Given this list of marker genes Flcn, Ulbp1, Naa60, Pilra, Adap2, Cmklr1, Cd83, Irak4, Ptafr, Vwa5a, Lair1, Ptprcap, Rab7b, Gm11613, Gpr65, Fcgr2b, Napsa, Trim5, Ly86, P2ry13, Naip2, Tep1 (telomerase associated protein 1), Il1a, Slc22a3 (solute carrier family 22 (organic cation transporter), member 3), Arrb2, Sp110, Tbc1d4, Arhgap4, Rnf166, Ms4a6d, Ctsz, Asah1, E330020D12Rik, Naip6, Tmcc3, Gm21057, Snx8, Sp140, Cfp, Ccr1, Selenop, Clec5a, Dock10, Ncr3-ps, Fnbp1, Vsir, Pparg, Ctsd, C130050O18Rik, P2ry6, Clec4a3, Gm14221, Tmem141, Casp1, Laptm5, Cd48 (CD48 antigen), Mertk, Alpk1, Cnbd2, Tmem104, Ccr5, Tnfrsf11a, Dock2, Stk10, Cd37, Clta, Slc15a3, Gm5834, Tmem268, Adgre1, Osbpl8, Tpbgl, Tfe3, Pla2g15 (phospholipase A2, group XV), Paqr7, Fcgrt, Rubcnl (RUN and cysteine rich domain containing beclin 1 interacting protein like), Gm16124, E230029C05Rik, Lpar5, Slfn8, Cd53, Batf, Dynlt1a, Gm6213 (predicted gene 6213), Nfkbid, Grk2, Il10ra, Cyp27a1, C5ar1, Gpr174, Mast3, Ffar2, Psd4, Crlf2, Fcrl2, Rac2, Pacc1, Tcirg1, Cd52, Tpm3, Nlrp3, Il12rb2, Apbb1ip, Fcgr1, Plcg2, Hpgds (NCBI Gene Id 54486), Gab3, Nceh1, Nlrp1b, Gpr160, Trem6l, Flt3, Ly9, Haus4, Ms4a4c, Apoe (apolipoprotein E), Themis2, Milr1, Maf, Gusb, Adam3, Tnfrsf26, Fyb1, H60b, Themis, Csf1r, Cgas, Nlrc5, Ctsa, Cd28 (CD28 antigen), Slc40a1, P2rx7, Ptprc, Rnf213, H2-K1, Zfp729a, Capza2, Ccl6, A130048G24Rik, Mef2c, C1qa, Cst3 (NCBI Gene Id 13010), Gpr141, Ifi207, Hexb, Cyth4, Cyba, Efhd2, Csf3r, Plcl2, Hexa, Ticam2, Slc37a2, Cracr2b, Ccr2, Tubgcp5, Ptk2b, Tfec, Mndal (myeloid nuclear differentiation antigen like), Lsp1, Vps33a, C3ar1, Morc3, Myo5a, Arhgef6, Cyfip1, Il6ra, Parp14, Sirpa, 1700099I09Rik, Anapc15, Card11, Hk3, Tbc1d22a, Clec10a, Casp4, Grn, Xaf1, Cln3, Clec2g, Ccl2, Dnmt3b, Fcrl1, Dtx3l, Fmnl1, Zfp992, Tmem87b, Tap1, A130071D04Rik, Ebi3, Adgb, Epsti1, Mpeg1, Ifi204, Calhm2, Ncf2, Clec4a1, Gm15987, Zbtb34, Sumf1, Gpr183, Cd86, Cytip, Gm28874, Il16, Cebpb, Rab32, Hmox1, Myo1g, Gpr34, Sell, Cd200r1, Slc11a1, Tpd52, Cyrib, Hdac9, Ifngr1, Prkcd, Myd88, Stk17b, C920009B18Rik, Abcb1b, Myo1f, Vav1, Pik3r5, Prkcb, Rab20, Ddx60, 4930473A02Rik, Tasl, Mrpl2, Ms4a4a, Map3k8, Cybb, Runx3, Il13ra1, Scoc, Ptpra, Ccl24, F13a1, Tmem273, Evi2b, Gmip, Zc3h12d, Orai2, Cd244a, Slc9a9, Pkd1l2, Cd300lf, Ifitm3, Ccdc93, B2m, Ccdc88b, Sat1, Tcf24, Elf4, Aga, Arpc1b, Gvin-ps6, Cd5l, Rhoh, Rgs14, Ctsh, Otulinl, Herc6, Pycard, Kcnab2, Sp100 (nuclear antigen Sp100), Havcr2, Pld2, Itk, Rreb1, Ifih1, Trim30d, Ighm (NCBI Gene Id 432703), Psap, Pik3cg, Helz2, Fkbp15, Akr1b10, Lgals8, Parvg, Aoah, Tesk2, Smim12, Arhgap15, Atxn7l1os2, Acap1, Unc93b1, Fgd2, Ms4a14, 9930111J21Rik2, Ctss, Il1rl2, Cd69, A630081D01Rik, A630001G21Rik (RIKEN cDNA A630001G21 gene), Stat1, Adap2os, Gm2a, Abcc3, Ocel1, Plcb2, Snx2, Lamp1, Cpa3, Gm16845, Rasa4, Cd27 (CD27 antigen), Fcna, Nr1h3, Rasal3, Tmem156, 2210408F21Rik, Plekha2, Itgb7, Skap2, Galnt6, Shcbp1l, Madd, 4933406I18Rik, Cysltr1, Slc17a5, Tifab, Trim30c (NCBI Gene Id 633513), Gm15644 (predicted gene 15644), Armc7, Snx20, Gbgt1, Lrrc25, Gm20559, Shisa5, Gsdmd, Aif1, Cmtm7, Pld4, BE692007, Pyroxd2, Myb, Tbc1d13, Dnase2a, Itgam, Cd84, Pkn1, B230307C23Rik, Erp29, Gm23677, Trim12a, Apobec3, Kcnk12, Jak3, Il4 (interleukin 4), Selplg, Arhgap17, Dennd4b, Stard8, Neat1, Cd44, Patl2, Fchsd2, Slc29a3, Nrros, Dock8, Mx1, Bach2os, Wdfy2, Pip4p1, Irf8, Slc16a7, Dennd1c, Evi2, Hpgd, Tlr13, Itm2b, Fuca1, Arrdc1, Tcn2, Arhgap9, Fxyd5, Pfkfb3, St6galnac4, Hmgb1-ps8, Plgrkt, Sash3, Akap10, Ptpn18, Eif2ak2, Slc25a45, Arhgap25, Pstpip1, Adora3, H2-D1, Sdcbp, Icos, Lpxn, Tlr4, Rnf13, Gm15964, Abcg3, Naip5, Ctsb, Cd36, Rhog, Pstpip2, Cx3cr1, Trim65, Lcp2, Nagpa, 4933406J09Rik, Il4ra, C1qc, Cma1, Ppm1h, Lgmn, Tnfrsf1b, Lrmda, Il18, Cd300c2, Clec7a, Hint2, H2-M3, Trbc1, Il15, Ms4a7, Gm26626, Ntpcr, Pepd, Cerk, Ncf1, Mir223hg, Glipr1, Cd68, Gvin-ps7, Inpp5d, Gpr171, Nfatc2, Alox5ap, Mfsd1, Clec4a2, Ptpn6, Ptgs1 (prostaglandin-endoperoxide synthase 1), Hgsnat, Coro7, Fcer1g, Gm28417, Cd79b, Vrk2, Capzb, Blvra, Ctsc, Casp8, Atg7, Coro1a, Glb1, Msr1, Ifnar2, Irf9, Nhlrc3, Ifi202b, 6430710M23Rik, Lyve1, Manba, Man2b1, BC035044, Ly6e, C1qb, Ms4a6b, Slfn2, Mpo, Ramp1 (NCBI Gene Id 77677), Vps26a, Parp8, Pdxk, Reps2, Adam17, Mrc1, Nlrc4, Emp3, Fes, Timd4, Il17ra, Jdp2, Slc46a3, Atmin (ATM interactor), Hfe, Abhd12 (NCBI Gene Id 99394), Ms4a6c, Ccl9, Il18r1, Mctp1, Fnip2, Cd33, Lgals3, Stap1, Gmfg, Wwp1, Actr3, Rab29, Litaf, Slfn3, Def6, Nfam1, Lrch4, Apobec1, Cd300a, Nckap1l, Lipe, Abr, Cryl1, Tpp1, Rel (reticuloendotheliosis oncogene), Tespa1, Il21r, Or5v1b, Snx6, Rftn1, Gm16712, Rnase4, Cd74, Dse, Engase, Psmb8, Il1rl1, Gm12185, Trpm2, Spi1, Fancg, Cfh, Grb2, Hck, Clec4n, Mlkl, Gvin3, Gm13710, Trem2, Erap1, Abcd1, Adap1, Il7r, Pik3cd, Ppp1r21, Cd80, Cd180, Psme2b, Nagk, Neurl3, Gm2245, Tlr1 (NCBI Gene Id 21897), Tbc1d5, Snx24, Rnf135, Gna15, Tbc1d14, Gas6, 2310001H17Rik, Oas2, Bank1, Gm26520, Gm26510, Arsb, Tyrobp, Ifi203, Lst1 (NCBI Gene Id 16988), Tlr2, Amz1, Nlrp1c-ps, Ugt1a7c, Zfp710, Ifngr2, A530072M11Rik, Ly96, Adgrg5, Gm15542, Ptpn22, Map3k5, Vps18, Arid5a, Gm26740, Il3ra, Slc38a6, Pip4k2a, Cebpzos, Il10rb, Lpcat2, Traf3ip3, Lyn, Ptger1, Ccl3, Hdc, Arhgap30, Plac8, Snx30, Hps3, Zc3h12a, Stab1, Cracr2a, Hcls1, Klk8, Ehd4, Spns3, Ang, Samhd1, Gbp7, Dclre1c, Tlr7, Cela1, Rnpep, Spic, Wdfy4, Itgal, Tmem86a, Fam111a, AB124611, Iqgap1, Npl, Plxdc1, Tap2, Tmem144, Adgre4, C030034L19Rik, Irf1, Pik3ap1, Evi2a, Dab2, Irf5, Siglech, 1700030C10Rik, Btla, Samsn1, Fcgr3, Blnk, P2ry12, 2310008N11Rik, Il18rap, Slco2b1, Gm35154, Rbpj, Tmem106a, Pgap6, Psma8, here is a description of the gene set: Mouse Gene Set: DESCARTES_ORGANOGENESIS_WHITE_BLOOD_CELLS from publication Cao J, Spielmann M, Qiu X, Huang X, Ibrahim DM, Hill AJ, Zhang F, Mundlos S, Christiansen L, Steemers FJ, Trapnell C, Shendure J (PMID 30787437) Mouse Organogenesis Cell Atlas (MOCA) DE_gene_main_cluster.csv, fold.change>=1.5, qval<0.05, pval<0.05 studied in species Mus musculus